The following is a description of a gene set: Any process that activates or increases the frequency, rate or extent of cold-induced thermogenesis. studied in species Mus musculus Mouse Gene Set: GOBP_POSITIVE_REGULATION_OF_COLD_INDUCED_THERMOGENESIS, and this is the list of marker genes: Hdac3, Vegfa, Il4ra, Dync1h1, Epas1, Lcn2, Adcyap1, Trpv2, Phox2b, Ehmt1 (NCBI Gene Id 77683), Alpl, Adrb2, Ache, Adrb3, Jak2, Fgf21, Trpm8, Ucp2, Mfap2, Decr1, Hsf1, Kdm3a, Dio2, Gadd45g, Ppargc1a (NCBI Gene Id 320239), Il18, Apc, Oxtr, Prkab2, Dbh, Letmd1, Bscl2, Ucp1, Igf1r, Fabp5, Oma1, Prkab1, Ogt, Sln, Prlr, Lepr, Pdgfc, Ybx2, Sfxn5 (sideroflexin 5), Ebf2, Tshr, Gatm (glycine amidinotransferase (L-arginine:glycine amidinotransferase)), G0s2, Fabp4, Cebpb, Elovl3, Sirt6, Zbtb7b, Il13, Esrrg, Mfn2, Prdm16, Cav1, Oxt, Ffar4, Appl2, Cd36, Kdm1a (lysine (K)-specific demethylase 1A), Scd1, Gnas, Gpr3, Adipoq, Per2, Hadh, Fh1, Cxcr4 (C-X-C motif chemokine receptor 4), Ppargc1b, Acsl1, Irf4, Elovl6, Alms1, Zfp516, Adipor2, Stat6, Plac8, Ksr2, Hcrt, Il4, Pth2r, Lep, Thra (NCBI Gene Id 319227), Lpin1, Adipor1, Cpt2 (NCBI Gene Id 12896), Pemt, Gja1, Kdm6b, Ccr2, Cnot3, Acadl, Smarca4, Ghrl, Adrb1, Syk, Cmklr1, Grb10